Given this list of marker genes CAD, CD1A, GTPBP6, RUFY1, P4HA2, MYL3 (myosin light chain 3), TTC4, GGA1, DMWD, PARP1, INTS3, HDAC6, APOBEC3G, FABP5, HLA-DPA1, ENDOD1, MTSS1, IGLV1-44, NDUFB8, GPR75, KLHL11, ITGB1BP2, DNAJC11, PXMP2, FAM200C, PHACTR4, GUSBP11, LTB (lymphotoxin beta), PRIM1, FAM3C, SEC14L5, GNB5, AIRIM, USP2, ABCB9, CHMP7, EIF2AK3, MTFR1, SRRT, RPUSD2, GPRC5D, DOP1B, PRG4, DUS2, ZDHHC4, SLC17A1, RPS2P45, TP63, CLN8, GH1, GEMIN4, OLFML2B, GAK, IGFLR1, TNFRSF1B, CBX7, HLA-DRB1, GRK5, LARP1, ACOT8, CORO7, TCFL5, SDR39U1, MRTFB, AMPD2, PPP3CC, TMEM156, PPAT, HESX1, BRD3OS, THADA, RASGRP2, MTCL1, SLC41A3, PLCH2, HDHD5, ARHGEF9, EEF1B2, FOLR1, LTA4H, WDR77, MTMR4, OGFOD3, TMEM243, GRK3, LY9, GGA2, SSX7, ADGRV1, EIF3B, C1orf216, DBNDD1, SYT17, PPFIBP2, TCF3, RGS4, BACH2, ENTREP1, ERCC6, PABPC4, NDUFA8, CPLANE2, RPS21, SHMT2, PPT1, FAM193A, ASCC3, PLPP1, PMS2P1, FANCG, PLA2G2F, IRF8, NUDCD3, RXYLT1, HLA-DRB6, CALB2, RPP38, ABCF2, CAMK2A, MTAP, TTPAL, NASP, MLYCD, SEMA3G, ATP10A, SLC25A4 (NCBI Gene Id 7872), NLRP2, SETBP1, TSPAN3, MTNAP1 (mitochondrial nucleoid associated protein 1), ZBP1, PLAAT3, SEMG1, NUBP2, SCLY, LRRC23, COQ6, MAGEC2, CD83, CRYL1, NOP56, GAA (NCBI Gene Id 2548), SMPD2, IKBKE, MZF1, PSD4, MFHAS1, CA5BP1, GLB1L2, SLC7A4, SRPRB (NCBI Gene Id 58477), KRT37, CRIP2 (cysteine rich protein 2), LPCAT3, JAM3, IGKC, RUBCNL, FBXO21, ASAP1, ILF3, ART1, CSNK1G2, CLUH, DNPH1, FCMR, PFN2 (NCBI Gene Id 85837), HS3ST1, ZNF202, PLEKHJ1, PGAP3 (post-GPI attachment to proteins phospholipase 3), BFAR, EPS8L3, ZNF473, TTC9, TEX10, TRIM25, CD72, KPNA2, ST13, MCF2L, DCLRE1C, TOMM70, SPATS2, AK2, CCDC9, TOMM34 (translocase of outer mitochondrial membrane 34), APOO, HPSE, CYLC2, PLPP3, ANTKMT, GABRA2, IGHV5-78 (immunoglobulin heavy variable 5-78 (pseudogene)), PRSS50, PEBP1, TRADD, MAVS, SZT2, here is a description of the gene set: Human Gene Set: GSE3982_BCELL_VS_BASOPHIL_UP Genes up-regulated in comparison of B cells versus basophils. studied in species Homo sapiens In the present study we used Affymetrix oligonucleotide microarrays to produce gene transcription profiles for the major leukocyte types in humans. This comprehensive dataset enabled us to not only establish which genes were expressed in each leukocyte type, but also which genes were expressed in each subset after activation. The used of a comprehensive dataset of gene profiles from all the major human leukocyte subsets enabled a novel and powerful means for identification of genes associated with single leukocyte subsets, or different immune paradigms. from publication Jeffrey KL, Brummer T, Rolph MS, Liu SM, Callejas NA, Grumont RJ, Gillieron C, Mackay F, Grey S, Camps M, Rommel C, Gerondakis SD, Mackay CR (PMID 16474395)